Given this list of marker genes Meis1, Ddx39b, Ang2, Asb2, Sorbs2, Dicer1, Rgs2 (NCBI Gene Id 19735), Dyrk1a, Gsk3a, Hey2, Actc1, Prickle1, Igf1, Ccn4, Gata4, Cavin4, Jag1, Xirp1, Atg7, Akap13, Adprhl1, Prox1, Zfp418, Pbrm1, Hamp2, G6pd2, Yy1, Hdac2, Myo18b, Large1, Gsk3b, Tgfbr3, Edn1, Mir208a, Myh10, Myh11, Cxadr, Pdcd4, Hnrnpu, Lrrc10, Actn2, Inhba, Tcap, Speg, Cdk1, Csrp3, Smad4, G6pdx, Rbm10, Pdgfra, Cav3, Smad6, Parp2, Sgcd, Adra1b, Ppara, Neb, Ctdp1, Camk2d, Mylk3, Slc25a4, Agtr2, Pi16, Spry1, Foxp1, Atg5, Mef2a, Isl1, Myl2, Nr3c1, Map2k4, Bmp4, Agt, Nkx2-6, Tbx3, Popdc2, Fdps, Akap6, Adrb1, Nrap, Ttn, Sirt1, Tbx5 (T-box 5), Pin1rt1, Bmp10, Nebl, Rgs4, Met, Ctcf, Pak1, Prkg1, Slc8a1, Adra1a, Notch1, Col14a1, Fhod3, Acvr1b, Pdlim5, Lmna, Tbx18, Trip10, Naglu, Pitx2, Nkx2-5, Hamp, Bmpr1a, Tomm70a, Alpk2, Sgcb, Ep300, Vegfa, Pdgfrb, Myocd, Maml1, Pin1, Srf, Mtor, Fhl2, Zmpste24, Shox2, Alpk3, Plec, Myh6, Bves, here is a description of the gene set: Mouse Gene Set: GOBP_CARDIAC_CELL_DEVELOPMENT species: Mus musculus The process whose specific outcome is the progression of a cardiac cell over time, from its formation to the mature state. A cardiac cell is a cell that will form part of the cardiac organ of an individual.